The following is a description of a gene set: Monocyte-derived dendritic cells (DC) and macrophages (MΦ) generated in vitro from the same individual blood donors were exposed to five different pathogens, and gene expression profiles were assessed by microarray analysis. Responses to Mycobacterium tuberculosis and to phylogenetically distinct protozoan (Leishmania major, L. donovani, Toxoplasma gondii) and helminth (Brugia malayi) parasites were examined, each of which produces chronic infections in humans yet vary considerably in the nature of the immune responses they trigger. Genes down-regulated in comparison of macrophages exposed to L. donovani versus macrophages exposed to 5 worms/well B. malayi. Human Gene Set: GSE360_L_DONOVANI_VS_B_MALAYI_LOW_DOSE_MAC_DN from publication Chaussabel D, Semnani RT, McDowell MA, Sacks D, Sher A, Nutman TB (PMID 12663451) studied in species Homo sapiens, and this is the list of marker genes: GNAI2, PAF1, NRG1, TM9SF2, KRT2, SHC1, SMC4 (NCBI Gene Id 10593), PIM1, CELA2A, MICU1, FCN1, USF2, EPHB4, MACF1, ZNF202 (zinc finger protein 202), PTPN18 (protein tyrosine phosphatase non-receptor type 18), FXR2, H1-10, GTF2H1, GAK, SH3BP1, SEC13, PLA2G4A, IMPDH1, ACP2, PDCD11, COQ2, MUC6, METTL13, PPT1, NFE2L1, ENPP4, TPST2, AHSA1, PADI2, SAFB, DHX16, ACOT13, POLR2J, PLXNB2, QPRT, TRIM37, MRPL23, CDC123, TAF10, DLEC1, SNAPC5, CHST1, LRRC8B, ZRSR2P1, SAA1, PES1, BCL2L1, UQCRFS1, SEC61B, DUSP7, GORASP2, VAV1, CD37, FAM120A, FOXJ3, SH2B3, ABL1, LMO4, EEF2, PDCD10, SASH3, HEG1, RPS21, PBX2, ITGAV, NFYC, SULF1, SLC29A1, CCL18, CLEC10A, CFDP1, DDOST, ITPA, PTPRO, LSM4, RERE, CYBA, FBXW11, IRF7, GNA11, SELENBP1, NPRL2, AMHR2, RAB5A, PZP, DAP, IFNW1, SNX1, STK10, ZNF133, RHEB, SPINK4, SNRPD2, ZBTB24, SUSD5, PLP1, TSPO, TMED10, ANXA5, PHF1, NUDT21, CDA, ACTN1, CHD4, LRIG2, CLCN7, GLRA3, GOLGA1, H2BC21, PPP1R15A, RABGGTA, HLA-DQB1, TAB2, PRPS1L1, POP4, ADCYAP1R1, ADGRL2, GOLGA2, TMEM268, ARHGAP22 (Rho GTPase activating protein 22), VCP (valosin containing protein), PNRC1, MIA2, LDLR (low density lipoprotein receptor), PCMT1, SCN9A, TBP, SLC6A9, ADAM23, MRPL58, ZFHX3, TNFAIP2, BCL7B, SREBF2, RELA, ZNF384, POFUT2, SLC23A2, NCOR2, BST2, CLIC4, STARD3, TMEM184B, MRPS18B, PPP6R1, LMO2, KIFBP, ZNF451, CDK2AP2, ESR1, TUBGCP3, GFUS, TMEM131L, KLHL18, UBE2I, CDC42BPA, ARR3, GNRH2, USP10, IQSEC2, ACTR3, AASS, GNA15, REM1, SF1, FAM89B, NREP, NLRP3, DCHS1, AP3S1, TBCA, PYGM, MMACHC, KIF1B (NCBI Gene Id 57598), ZNF134, VPS52, CD40, NDUFS7, AP1B1, LPCAT3, DUSP3, ATXN2, DHX38 (NCBI Gene Id 9785), VDAC2, ALG3 (ALG3 alpha-1,3- mannosyltransferase), GLUD2, PCDH7, NIPSNAP2 (nipsnap homolog 2), CCT7, ITGAL, PTCH1 (patched 1), CHMP1A, SLC25A5